The following is a description of a gene set: The chemical reactions and pathways involving dicarboxylic acids, any organic acid containing three carboxyl (COOH) groups or anions (COO-). studied in species Mus musculus Mouse Gene Set: GOBP_TRICARBOXYLIC_ACID_METABOLIC_PROCESS, and this is the list of marker genes: Aco2, Asl, Sirt4, Cs, Csl, Pck1, Glud1, Idh2, Idh1, Aco1, Ass1, Idh3a, 4933405O20Rik, Idh3b, Idh3g, Acacb, Acly